The following is a description of a gene set: Human Gene Set: NADLER_OBESITY_DN Obesity is strongly correlated with type 2 diabetes mellitus, a common disorder of glucose and lipid metabolism. Although adipocytes are critical in obesity, their role in diabetes has only recently been appreciated. We conducted studies by using DNA microarrays to identify differences in gene expression in adipose tissue from lean, obese, and obese-diabetic mice. The expression level of over 11,000 transcripts was analyzed, and 214 transcripts showed significant differences between lean and obese mice. Surprisingly, the expression of genes normally associated with adipocyte differentiation were down-regulated in obesity. Not all obese individuals will become diabetic; many remain normoglycemic despite profound obesity. Understanding the transition to obesity with concomitant diabetes will provide important clues to the pathogenesis of type 2 diabetes. Therefore, we examined the levels of gene expression in adipose tissue from five groups of obese mice with varying degrees of hyperglycemia, and we identified genes whose expression strongly correlated with diabetes severity. This group included many genes that are known to be involved in signal transduction and energy metabolism as well as genes not previously examined in the context of diabetes. Our data show that a decrease in expression of genes normally involved in adipogenesis is associated with obesity, and we further identify genes important for subsequent development of type 2 diabetes mellitus. species: Mus musculus Genes down-regulated in adipose tissue from obese mouse strains compared to the lean ones. from publication Nadler ST, Stoehr JP, Schueler KL, Tanimoto G, Yandell BS, Attie AD (PMID 11027337), and this is the list of marker genes: UCK1, LDHB, RASD1, MYLK, HBB, ADRB3, FMO1, GBE1, AGT, DBI, SCD, APOE, B2M, SOD1, GNG11, MCCC1, FABP4, SREBF1, CFB, GNAI1, UBB, CYC1, ALDOA, UQCRC2, EEF1A1, ASNS, TSHR, FDFT1, CDKN2C, CYP2E1, RBP4, PCK1, NNAT, BCAT2, PC, GPD2, CFD, PYGB, COX8A, SDHB, HP, ACLY, PPA1, ATP5ME, RBMS2, ECHS1, ALDH2, DDT, THRSP (NCBI Gene Id 82916)